Given this list of marker genes Susd4, Cr1l, C4bp, Cr2, Cd46, Fcgr2b, Ptpn6, Foxj1, Zp3r, here is a description of the gene set: species: Mus musculus Any process that stops, prevents, or reduces the frequency, rate, or extent of a humoral immune response mediated by circulating immunoglobulin. Mouse Gene Set: GOBP_NEGATIVE_REGULATION_OF_HUMORAL_IMMUNE_RESPONSE_MEDIATED_BY_CIRCULATING_IMMUNOGLOBULIN